Given this list of marker genes Rpa1, Pcna, Pold1, Msh6, Pold2, Pold4, Msh2, Lig1, Pms2, here is a description of the gene set: electronically inferred by orthology from the curated human pathway part of: Mismatch Repair studied in species Mus musculus Reactome Pathway: Mismatch repair (MMR) directed by MSH2:MSH6 (MutSalpha) This event has been computationally inferred from an event that has been demonstrated in another species.<p>The inference is based on the homology mapping from PANTHER. Briefly, reactions for which all involved PhysicalEntities (in input, output and catalyst) have a mapped orthologue/paralogue (for complexes at least 75% of components must have a mapping) are inferred to the other species.